The following is a description of a gene set: studied in species Homo sapiens Human Gene Set: ACAGGGT_MIR10A_MIR10B Genes having at least one occurence of the motif ACAGGGT in their 3' untranslated region. The motif represents putative target (that is, seed match) of human mature miRNAs hsa-miR-10a and hsa-miR-10b (v7.1 miRBase)., and this is the list of marker genes: CELF6, MYCBP, SLC25A1, SRSF1, MAPRE1, BAZ1B, ARHGAP12, CSNK1G1, PRRT3, E2F3, LTBP1, BCL6, HS6ST2, POMT2, IL1RAPL1, IGSF1, TMOD1, DOCK11, ADGRL1, NFIX, ARK2C, NAA15, SDC1, PURG, CAMK2G, HOXA1, MDGA2, NACC1, HOXB3, FHL3, COPS7B (COP9 signalosome subunit 7B), GATA6, PURB, KLF13, BACH2, ASXL1, H3-3B, DAZAP1, HOXA3, ANKFY1, KL, SOBP, SVOP, ARRDC3, NCOR2, GRM3, CTDSPL, ELAVL2, TMEM121B, KCTD17, KCTD16, ABTB3 (NCBI Gene Id 440109), NR4A3, FLT1, ELAVL3, NFAT5, TRIM2, CSMD1, USP46, HSPA14, NFASC, HAS3, CADM1, GTF2H1, KLF11, TNRC6B, ARNT, TBX5, RAP2A, CELF2, SLC38A2, WDR26, HNRNPK, NRP2, USF2, ESRRG, POPDC2, SHISA7, NONO, PAFAH1B1, BTRC, MTMR3, MAP3K7, HIVEP2, ZNF367, FXR2, NCOA6, BDNF, ID4, ERI3, ZMYND11, CTNNBIP1, ELOVL6, RB1CC1 (NCBI Gene Id 9821), MAPKBP1, AFF4, FNBP1L, DVL3, H3-5, EPHA8, SIX4, KCNA6, SMAP1 (small ArfGAP 1), TFAP2C, BRWD1, CYTH1, TMEM183A, C14orf28, CDIP1, ITSN1, PPP1R14C, EPHA4, CNNM4 (NCBI Gene Id 619531), SON, CNOT6, ZNF608, RPRD1A, GALNT1, FIGN, APPBP2, WNK3, BAZ2B